Given this list of marker genes Cenpm, Cenpq, Tuba4a, Cenpe, Tuba8, Nup85, Smc3, Cdk1, Cenpn, Zwilch (zwilch kinetochore protein), Mad1l1, Firrm, Clasp1, Ndc80, Itgb3bp, Dynll1, Kif2c, Cenpu, Spc24, Tubb4a, Tubb6, Cenpt, Mad2l1, Rad21, Ska1, Nudc, Ppp2r1b, Tuba3b, Mis12, Ppp2r5d, Stag1, Xpo1, Kif2b, Cenps, Ppp2r5b, Tubal3, Hdac8, Tuba1a, Nde1, Nup133, Ndel1, B9d2, Kntc1, Tubb2b, Cenpa, Aurkb, Tuba1b, Dync1li2, Tuba1c, Ppp2r5a, Plk1, Seh1l, Tubb4b, Ccnb1, here is a description of the gene set: electronically inferred by orthology from the curated human pathway Reactome Pathway: Resolution of Sister Chromatid Cohesion This event has been computationally inferred from an event that has been demonstrated in another species.<p>The inference is based on the homology mapping from PANTHER. Briefly, reactions for which all involved PhysicalEntities (in input, output and catalyst) have a mapped orthologue/paralogue (for complexes at least 75% of components must have a mapping) are inferred to the other species. studied in species Mus musculus part of: Mitotic Prometaphase